Given this list of marker genes Irs1, Ngf, Pik3r2, Pik3cb, Irs2, here is a description of the gene set: electronically inferred by orthology from the curated human pathway This event has been computationally inferred from an event that has been demonstrated in another species.<p>The inference is based on the homology mapping from PANTHER. Briefly, reactions for which all involved PhysicalEntities (in input, output and catalyst) have a mapped orthologue/paralogue (for complexes at least 75% of components must have a mapping) are inferred to the other species. part of: Signaling by NTRK1 (TRKA) Reactome Pathway: PI3K/AKT activation studied in species Mus musculus